The following is a description of a gene set: studied in species Homo sapiens Genes having at least one occurence of the motif TAATGTG in their 3' untranslated region. The motif represents putative target (that is, seed match) of human mature miRNA hsa-miR-323 (v7.1 miRBase). Human Gene Set: TAATGTG_MIR323, and this is the list of marker genes: RSBN1, RAB1A (NCBI Gene Id 5861), PAK5, HIPK1, SEPTIN3, CHCHD4, TGFA, HS2ST1, MARCKSL1, FNBP1L, FBN2, MAPRE1, RPS6KA3, CSNK1G3, CPEB4, NRK, RAB11FIP2, NSD2, REV3L (NCBI Gene Id 7807), ULK2, ARFIP1, HOXA1, MCFD2, LCLAT1, FEM1B, BORA, DPF2, EIF3J (NCBI Gene Id 8669), RANBP9, FGD4, HEXIM1, GJA1, CLASP1, PTK2B, NT5C3B, LRRC4, WTAP, KCNJ3, SLMAP, AFF4, RCN1, ENTPD5, CUL1, ATP11B, ZIC1, DIP2C, CEPT1, NFIX, CCND1, FCHO2, TMED7, SLITRK2, RNF214, NUAK2, IRF2BPL, CCDC117, UBE2O, ADAMTS6, POU4F2, CREB1, CCDC6, MRC1, KDM6A, USF3, KPNA1, FAM135A, MYLIP, ZEB2, TGIF1, PCNX2, NDEL1, AKIP1, NR4A3, NKAIN2, CDKN1B, ZNF318, MAP4K4, CBFA2T3, ACAT2, BTAF1 (B-TFIID TATA-box binding protein associated factor 1), OSBP, RPGRIP1L, CXCL12, G3BP2, PPP1CB, PCDH9, GPM6A, ARGLU1, PITPNA, TMPO, VGLL3, NUFIP2, EGR3, PKP4, SEMA6D, AUH, DCUN1D1, INTU, ZMYM2, SLC4A4, NFAT5, ANKRD27, TEAD1, ZC2HC1A, EBF3, SETD7, TOP1, PPARGC1A, PJA2, NFKB1, STAT5B, SUCO, TBPL1, WBP2, FBN1, CAMTA1, HOXB5, PPP4R4, LPP, ZDHHC21, FANCI, KPNA3, HOOK3, STX12, SRSF1, TNRC6A, RADX, USP9X, PHF21B, POU2F3, UBL3, CRK, STK35 (serine/threonine kinase 35), ANKHD1, CLCN3, HAPSTR1, SPSB4, SMARCAD1, TRIM33, VPS26B, USP46, ZHX1, RAB10 (RAB10, member RAS oncogene family), DDX3X, PDCD10, ZBTB2, UHRF2, QSOX2, ARHGAP20 (NCBI Gene Id 57569), ANO4, TMOD1, TOP2B, NPR3, YEATS2, FAM20B, LARP1B, DHX36, SUMO1, MAP3K3, SATB1, BET1, ASF1A